Given this list of marker genes SMARCE1, CSPP1 (centrosome and spindle pole associated protein 1), POLR3A, GMPPB, DDX3X, EXOSC9, PHGDH, IFT80, SMARCB1, PDHA1, TRIP13, ATP6V1E1 (ATPase H+ transporting V1 subunit E1), WDR73, FGFR1, PMM2, AFF3, TSEN15 (NCBI Gene Id 92120), MTM1, PIEZO2, TXNDC15, TMEM107, ARID1A, TMEM67, POMT1, NRAS, NPHP3, AP1S2, GJB6, TMEM231, AHDC1, BUB3, SLC35A2, DPF2, EBP (NCBI Gene Id 139151), VRK1, ARID2, IGF2, MUSK, DENND5A (DENN domain containing 5A), LONP1, MAB21L1, TMEM216, CEP290, SEMA3E, BLTP1, PGAP2, POMGNT1, GTPBP2, FAR1, HRAS, CDKN1C, B9D2, FKRP, POLR1A, PPP1CB, CCDC22, B3GALNT2, ATP6V1A, WDR81, TMTC3, KCNQ1, RPGRIP1, VPS35L, GPC3, HYLS1, CDC42, MID1, OFD1, TCTN1, KIF5A, COG8, TCTN3, SOX4, BUB1B, ALG3, DPH2 (diphthamide biosynthesis 2), WASHC5, DPH1, KRAS, KIF7 (NCBI Gene Id 46), CC2D2A (coiled-coil and C2 domain containing 2A), CEP57, C2CD3, FTO, CSF1R, TCTN2, LAMA1, ESCO2, DHCR7, GRM1, CEP120, TUBA1A, PIGN, RPGRIP1L, SMG9, ZSWIM6, SLC18A3, SOX11, GLI3, OPHN1, ARID1B (NCBI Gene Id 645070), POMGNT2, ATP6V1B2, DOK7, SEPSECS, LARGE1, GPC4, B9D1, EVC (NCBI Gene Id 7886), TMEM237, DYNC2H1, POMK, SNX14, GJB2, RXYLT1, AGTPBP1, CPT2, DAG1, TMEM138, BCOR, MKS1, KIF21A, VPS51, DOCK6, ARMC9, TSEN54, FKTN, SMARCC2, TUBB, NUP88, BUB1 (BUB1 mitotic checkpoint serine/threonine kinase), POMT2, COL3A1, B4GAT1, KCNQ1OT1, DPYSL5, WDR35, EXOSC3, RNF113A, TSEN34, PDGFRB, PLCH1, MAGEL2, POGZ (pogo transposable element derived with ZNF domain), COL4A1, TSEN2, FLVCR2, ATP6V0A2, CRPPA, EXOSC8, CHD7, USP9X, SMARCA4, DYNC2I2, ZIC1, EVC2, SMARCD1 (SWI/SNF related, matrix associated, actin dependent regulator of chromatin, subfamily d, member 1), TBC1D24, GRIA3, MYOD1, B4GALT1, SLC25A46, DYNC2I1, KIAA0586, RAPSN, ASXL1 (ASXL transcriptional regulator 1), PLG, here is a description of the gene set: species: Homo sapiens Cerebellar cyst Human Gene Set: HP_CEREBELLAR_CYST